The following is a description of a gene set: The progression of the brainstem from its formation to the mature structure. The brainstem is the part of the brain that connects the brain with the spinal cord. Mouse Gene Set: GOBP_BRAINSTEM_DEVELOPMENT species: Mus musculus, and this is the list of marker genes: Atic, Atf2, Smad4, Nlgn4l, Cntfr, Phox2b (NCBI Gene Id 245706), Gart